Given this list of marker genes TBC1D8, MIER3, GLCCI1 (glucocorticoid induced 1), ASXL1, C11orf16, LRRC57, NACA, DIP2B, RBMXL1, FGFBP2, MOSPD1, TRIM7, ZNF536, DZIP3, SESTD1, RGSL1, TGFBR1, FKTN, BAGE2, NFIB, ZBTB10, CNOT4, SEL1L, H3-3B, PDGFRB, MXI1, ITGB1BP1, TOX3, TMEM237, GCC1, USP37, ATP6AP2, VSTM4, B4GALT1, ID4, TMEM68, AK4 (adenylate kinase 4), GOLGA7, ACP6, UBE4B, GMCL1, ABCD2, MT1M, SMAD3, DPP6, WAPL (WAPL cohesin release factor), SANBR, KCNH5, KCNV1, S100PBP, UBE2QL1 (NCBI Gene Id 134111), DCUN1D5, HHAT, RBMX, BMS1 (NCBI Gene Id 9790), ZNF226, CCDC15, FGD4, DCAF12, FPGT, SPG7, here is a description of the gene set: species: Homo sapiens Human Gene Set: MIR668_3P from publication Chen Y, Wang X (PMID 31504780) Genes predicted to be targets of miRBase v22 microRNA hsa-miR-668-3p in miRDB v6.0 with MirTarget v4 prediction scores > 80 (high confidence targets).